Given this list of marker genes ABL1, PLAU, ITGB7, TSPAN32, MPIG6B, ITGB4, CD47, CEACAM1, LAMA5, LAMA1, LOXL3, ITGA2, FUT8, PTPRA, HCK, FBLN1, BCAR1, APOA1, ITGB1BP1 (NCBI Gene Id 9270), CUL3, CD63, FGR, DAB2, MADCAM1, ITGA4, SYK, ITGB8, ITGAE, PTK2B, SEMA7A, ADAM9, SLC2A10, NEDD9, TEC, ANGPTL3, PLEK, ZYX, ADAMTS1, PTN, NME2 (NCBI Gene Id 4831), MIR92B, ADAM15, VAV3, PTPN11, LAMA2, ITGAL, ITGA9, ITGAD, COL3A1, ITGA3, ADAMTS13, PRKD1, ITGB6, ADAM11, CCN1, ITGBL1, ITGA8, ITGA1, TIMP1, PHACTR4, ERBIN, ILK, LIMS2, PLPP3, PRAM1, DST, FLNA (filamin A), CDC42, CD40LG, ZNF304, FN1 (fibronectin 1), MYH9, SRC, NRP1, FYB1, ITGB1, THY1, VAV1, ITGA10, NID1, LAMB1, VTN, EMP2, ITGA5, CCM2, ITGA2B, CDH17, FCER1G, TYROBP, LIMS1 (LIM zinc finger domain containing 1), ISG15, BST1, CD177, DIAPH3, FERMT2, LAMB2, SERPINE1, ITGAM, CCN2, ITGA11, ADAM10, ITGA6, CTNNA1, ITGB2, ITGAX, ITGB5, FERMT1, DOCK1, COL16A1, ITGAV, LAT, FERMT3, LAMC1, RCC2, FYB2, ITGB3, TLN1, PTK2, ITGA7, here is a description of the gene set: Human Gene Set: GOBP_INTEGRIN_MEDIATED_SIGNALING_PATHWAY studied in species Homo sapiens The series of molecular signals initiated by an extracellular ligand binding to an integrin on the surface of a target cell, and ending with the regulation of a downstream cellular process, e.g. transcription.